Given this list of marker genes COPS7B, API5, ZG16, CWC25 (CWC25 spliceosome associated protein homolog), GM2A, ACOT11, TGIF1 (NCBI Gene Id 91941), FSTL3, CCDC47, here is a description of the gene set: species: Homo sapiens from publication Chen Y, Wang X (PMID 31504780) Genes predicted to be targets of miRBase v22 microRNA hsa-miR-4707-5p in miRDB v6.0 with MirTarget v4 prediction scores > 80 (high confidence targets). Human Gene Set: MIR4707_5P